Given this list of marker genes PROM1 (prominin 1), HLA-DQB1, MPO, AIF1, SORL1, JCHAIN, HLA-DQA1, CEP15, GZMB, SPINK2, HLA-DRB4, PLS3, here is a description of the gene set: Human Gene Set: GRAHAM_CML_QUIESCENT_VS_NORMAL_DIVIDING_DN Quiescent and dividing hemopoietic stem cells (HSC) display marked differences in their ability to move between the peripheral circulation and the bone marrow. Specifically, long-term engraftment potential predominantly resides in the quiescent HSC subfraction, and G-CSF mobilization results in the preferential accumulation of quiescent HSC in the periphery. In contrast, stem cells from chronic myeloid leukemia (CML) patients display a constitutive presence in the circulation. To understand the molecular basis for this, we have used microarray technology to analyze the transcriptional differences between dividing and quiescent, normal, and CML-derived CD34+ cells. Our data show a remarkable transcriptional similarity between normal and CML dividing cells, suggesting that the effects of BCR-ABL on the CD34+ cell transcriptome are more limited than previously thought. In addition, we show that quiescent CML cells are more similar to their dividing counterparts than quiescent normal cells are to theirs. We also show these transcriptional differences to be reflected in the altered proliferative activity of normal and CML CD34+ cells. Of the most interest is that the major class of genes that is more abundant in the quiescent cells compared with the dividing cells encodes members of the chemokine family. We propose a role for chemokines expressed by quiescent HSC in the orchestration of CD34+ cell mobilization. Disclosure of potential conflicts of interest is found at the end of this article. Genes down-regulated in quescent CD34+ cells isolated from peripheral blood of CML (chronic myeloblastic leukemia) patients compared to the dividing cells from normal donors. studied in species Homo sapiens from publication Graham SM, Vass JK, Holyoake TL, Graham GJ (PMID 17717066)